Given this list of marker genes MCM4, KIF15, ECT2 (epithelial cell transforming 2), CENPF, E2F7, ESM1, UBE2C, RNF216, NUP107, RUVBL1, NOTCH1, CEP192, H3-3A, MYBL2 (NCBI Gene Id 4605), CASTOR3P, ACTL6A, LIN9, TPX2, SMOC2, TOP2A, INO80D, KIF20B, CCNA1, GATD3, H4C16, APC, S100P, AURKA, here is a description of the gene set: studied in species Homo sapiens Human Gene Set: WP_GASTRIC_CANCER_NETWORK_1 Gastric cancer network 1